The following is a description of a gene set: studied in species Homo sapiens Human Gene Set: HP_POOR_FINE_MOTOR_COORDINATION Poor fine motor coordination An abnormality of the ability (skills) to perform a precise movement of small muscles with the intent to perform a specific act. Fine motor skills are required to mediate movements of the wrists, hands, fingers, feet, and toes., and this is the list of marker genes: ATP9A, TPM2, TPM3, DARS2, SNORD116-1, DCC, MAGEL2, SCN9A, DMPK, NPAP1, DNAL4, RNU12, GNB5, THG1L, PDHX (NCBI Gene Id 8050), PWRN1, RAD51, MFN2 (mitofusin 2), ADGRV1, GABRA1, SNORD115-1, CUX1, FOCAD, GNE, PCDH19, MYPN, PIEZO2, EBF3, SCN1A, GABRG2, FOXP2, NEB, PRRT2, VCP, MTRFR, NTN1, KBTBD13, HERC2, GDAP1, DLK1, SCN1B, HCN1, SLC2A3, MKRN3 (NCBI Gene Id 7681), PRNP, KLHL41, RAI1, GABRD, SLC30A10, FMR1, SBF2, MMACHC, HTT, FGF13, RDH11, RTL1, CXCR4, PWAR1, EZH2, FXN, ACTA1, SCN2A, PPP2R2B, ZEB2, MEG3, STX1B, ALMS1 (ALMS1 centrosome and basal body associated protein)